The following is a description of a gene set: Human Gene Set: GOBP_REGULATION_OF_XENOPHAGY studied in species Homo sapiens Any process that modulates the frequency, rate or extent of xenophagy., and this is the list of marker genes: MAPK3, LRSAM1, TBK1, OPTN, RIPK2, RNF31, NOD1, IRGM